The following is a description of a gene set: Posterior synechiae of the anterior chamber Adhesions between the iris and the lens. Human Gene Set: HP_POSTERIOR_SYNECHIAE_OF_THE_ANTERIOR_CHAMBER studied in species Homo sapiens, and this is the list of marker genes: RPE65, SPATA7, FAS (NCBI Gene Id 355), LARGE1, ADAMTS17, CYP1B1, ATOH7, LRAT, PTPN22, LCA5, MIR204, FOXE3, HMX1, FOXC1